The following is a description of a gene set: Mouse Gene Set: GOBP_POSITIVE_REGULATION_OF_EXTRACELLULAR_MATRIX_ORGANIZATION studied in species Mus musculus Any process that activates or increases the frequency, rate or extent of extracellular matrix organization., and this is the list of marker genes: Bmp2, Il6, Tgfb2, Cpb2 (NCBI Gene Id 93820), Smad3, Meltf, Agt, Clasp2, Sema5a, Sox9, Tnxb (NCBI Gene Id 81877), Tgfb1, Efemp2, Cyp2j6, Emilin1, Rb1, Smad4, Carmil2, Pdpn (podoplanin), Ddr2 (discoidin domain receptor family, member 2), Clasp1, Dag1, Ier3ip1 (immediate early response 3 interacting protein 1), Mad2l2, Rgcc, Fscn1, Cflar, Colgalt1, Phldb2, Phldb1, Abl1, Tgfbr1